Given this list of marker genes ARHGAP29, ACY3, ASF1A, ADAMTSL3, CCDC152, CD40LG, MCUB, CCDC97, AGK, LINC02880, DNAJC28, CACNG7, ETV6, CRYBG1, DNAJC9, ASB15 (NCBI Gene Id 142685), DPYS, CD248, EEF1E1, ARL6IP6, CST11, ATP6V0C, ELAC1, DNAJB14, CSNK1G3, C1orf122, CCNF, ERLEC1, CALCA, CDK1, CNPY1, BBOX1, ZGRF1, CUBN, ADAMDEC1, CST3, DGCR5, CCDC136, FBXW5, THEMIS2, ALX4, ASCL3, COMMD5 (NCBI Gene Id 90980), GPAT4 (NCBI Gene Id 574440), AMPD2, AVEN (NCBI Gene Id 57099), EIF3J, CLEC7A, EOMES, LINC01949 (NCBI Gene Id 55338), TMA7, FAM47C, COMMD7, BEND4, C2orf15, BCL2L14, FDCSP, E2F1, AGPS, FAM47A, C4orf36, ARHGEF19, CDIPT, CC2D1B, COPG1 (NCBI Gene Id 51137), AP1M1, DMTN, ANK1, CPNE3, CABP2, FBXL14, CEP164, CPLX2, ACAT1, CECR2, MUCL3, ANGPT4, EYA3, AMER2, BDNF, CLU, TMEM242, CES1, DNASE1L2, EXOSC1, ATF7, FBXW9, PRAMEF12, LINC03040, CHUK, ATP6AP1, RNF32-DT, CLDN2, DOHH, BHLHE22, ATXN1, CYP4Z1, CCDC88C, DOC2A, HTR5A, TEDC1, CENPN, CENPE, ATRN (NCBI Gene Id 8455), INHBE, ANXA4, KLHL30-AS1, DUSP14, ATXN3L (ataxin 3 like), BPI, ADAM9, ZNG1A, CCDC33, EFCAB10, NDNF, COTL1, FOS, CABLES1, CFAP47, CDH19, BID, CAMK1D, ALDH16A1, ARHGAP35, YWHAH-AS1, CHST12, BMS1P1, G3BP2, ASAP2, TBATA, CETN2, FBXO45, CPNE9, C9orf85 (chromosome 9 open reading frame 85), FAIM, COL5A1, SCN8A, CBY3, CSPG5, BAHD1, EIF5A2, ART4, CLEC14A, CD8B, CTNS, RMDN3, ALDH1L2, CRBN, CABS1, ADHFE1, AP3M1 (adaptor related protein complex 3 subunit mu 1), DCP2, ETV7, EIF3K, CHPF, ENTPD3, BOLA3, ABAT, CHRNA4, AFAP1, ARPIN, C1QTNF7, ELMO1, FAM83C, RHNO1, BMAL1, CYP2E1, EFR3A, SPRING1, CASP3, NOCT, CASP8, CYBC1, CXXC1P1, ENTPD1, FAM118B, ASMTL-AS1, ZBTB7C-AS2, C1orf210, CXCL14, BAZ1A, SPMIP10, ADAMTS5, FHL1, CR2, CTAG2, ADCY9 (adenylate cyclase 9), CHRNA1, COX7A1, CMTM5, COA3, BCL3, ADCY7, EXOC2, ARHGEF5, here is a description of the gene set: from publication Miyara M, Yoshioka Y, Kitoh A, Shima T, Wing K, Niwa A, Parizot C, Taflin C, Heike T, Valeyre D, Mathian A, Nakahata T, Yamaguchi T, Nomura T, Ono M, Amoura Z, Gorochov G, Sakaguchi S (PMID 19464196) Genes up-regulated in comparison of PTPRC- CD4 T cells versus PTPRC+ resting regulatory T cell (Treg). species: Homo sapiens Gene expression profiles of subsets of CD4+ T cells according to their expression of FoxP3 and CD45RA were compared. FoxP3 is a key transcription factor for the development and function of natural CD4+ regulatory T cells (Tregs). Here we show that human FoxP3+CD4+ T cells are composed of three phenotypically and functionally distinct subpopulations: CD45RA+FoxP3low resting Tregs (rTregs) and CD45RA-FoxP3high activated Tregs (aTregs), both of which are suppressive in vitro, and cytokine-secreting CD45RA-FoxP3low non-suppressive T cells. The proportion of the three subpopulations characteristically altered in cord blood, aged individuals, and patients with immunological diseases. Terminally differentiated aTregs rapidly die while rTregs proliferate and convert into aTregs in vitro and in vivo as shown by the transfer of rTregs into NOD-scid-common gamma-chain-knockout mice and by TCR sequence-based T cell clonotype tracing in peripheral blood of normal individuals. Taken together, the dissection of FoxP3+ cells into subsets enables one to analyze Treg differentiation dynamics and interactions in normal and disease states, and to control immune responses through manipulating particular FoxP3+ subpopulations. Human Gene Set: GSE15659_CD45RA_NEG_CD4_TCELL_VS_RESTING_TREG_UP